Given this list of marker genes CD68, LILRB2, CST7, FAM3D, SLC11A1, CCL19, FCGR2B, TREM2, CTSS (NCBI Gene Id 50653), FGL2, TAPBPL, CD74 (CD74 molecule), CCR7, WAS, HLA-DOA, THBS1, CCL21, NOD2, PYCARD, HLA-DOB, NOD1, HFE, YTHDF1 (NCBI Gene Id 54915), here is a description of the gene set: Human Gene Set: GOBP_REGULATION_OF_ANTIGEN_PROCESSING_AND_PRESENTATION Any process that modulates the frequency, rate, or extent of antigen processing and presentation. species: Homo sapiens